The following is a description of a gene set: Phosphorylation of CD3 and TCR zeta chains Mouse Gene Set: REACTOME_PHOSPHORYLATION_OF_CD3_AND_TCR_ZETA_CHAINS species: Mus musculus, and this is the list of marker genes: H2-Ab1 (histocompatibility 2, class II antigen A, beta 1), Trac, Cd3g, H2-Aa, Pag1, Cd3d (NCBI Gene Id 12500), Trbv16, H2-Eb2, Ptpn22, Cd4, Trbv15, Trav19, H2-Ea, Cd247, Lck, Cd3e, Trav16, Ptprc, Csk, H2-Eb1, Ptprj